The following is a description of a gene set: studied in species Homo sapiens Atrophy of the cerebral subcortical white and gray matter, termed subcortical atrophy, reflects loss of nerve cells in the basal ganglia or fibers in the deep white matter. Human Gene Set: HP_SUBCORTICAL_CEREBRAL_ATROPHY Subcortical cerebral atrophy, and this is the list of marker genes: MYO7A, TCTN3, WHRN, KRAS, ALG3, ADGRV1, USH1C, MAN2B1, USH1G, MYO5A, COG7, GCDH (glutaryl-CoA dehydrogenase), EHMT1, MBTPS2, SHPK, HNF1B, FGFR1, CIB2, ACTB, LHX1, ESPN, PCDH15 (protocadherin related 15), CDH23, PDZD7, POGZ, USH2A, ACTG1